The following is a description of a gene set: Human Gene Set: GOBP_CONDITIONED_PLACE_PREFERENCE The associative learning process by which an animal learns and remembers an association between a neutral, unchanging environment and a putatively rewarding, internal state produced by a xenobiotic or drug. studied in species Homo sapiens, and this is the list of marker genes: GRIA1, OPRK1, SLC1A1, SLC6A4, CSMD1